The following is a description of a gene set: Abnormal stool composition studied in species Homo sapiens Human Gene Set: HP_ABNORMAL_STOOL_COMPOSITION Abnormal level of metabolite or other abnormal analyte result in a stool test., and this is the list of marker genes: ALAD, DEF6, PTPN3, BRCA2, PPOX, SLC26A3, HSD3B7, RFX6 (regulatory factor X6), SLC9A3, CPOX, GATA1, MYO5B (NCBI Gene Id 4645), ROS1, UROS, EPCAM, UROD, CYP7B1, BRCA1, DCDC2, PERCC1, SLC10A2